The following is a description of a gene set: Human Gene Set: HP_ABNORMAL_URINE_MAGNESIUM_CONCENTRATION species: Homo sapiens Abnormal urine magnesium concentration An abnormal concentration of magnesium the urine., and this is the list of marker genes: SLC12A3, CLDN16, ATP1A1, FXYD2, CLDN19, KCNJ10, IFT122, GNA11, CASR